The following is a description of a gene set: Mouse Gene Set: GOMF_CATALYTIC_ACTIVITY_ACTING_ON_RNA Catalytic activity that acts to modify RNA. studied in species Mus musculus, and this is the list of marker genes: Rnasek, Yars2, Tmt1a2, Tgs1, Ddx46, Ear1, Gtdc1, Eif4b, Farsb, Ang4 (NCBI Gene Id 328486), Mettl5, Dhx30, Slfn4, Henmt1, Trmt5, Ddx31, Mov10l1, Ddx42, Trmt10a (tRNA methyltransferase 10A), Qrsl1, Rpp21, Tfb1m, Dhx57, Aqr, Aarsd1 (NCBI Gene Id 69684), Mars1, Ddx56 (DEAD box helicase 56), Ankzf1, Dhx58, Tert, Tsen2, Dus4l, Nudt16l2, Top3b, Isg20, Rnase6, Rnasel, Rnase11, Xrn2, Ang5, Nsun2, Rnase10, Nop2, Ddx24, Dhx9, Slfn14, Pif1, Trmt1l, Trmt11, Polr2k (polymerase (RNA) II (DNA directed) polypeptide K), Mrm2, Rnase2b, Ptrhd1, Cmtr1, Ptrh1, Ddx55, Thumpd3, Ddx3y, Dus2, Rnase2a, Mrm3, Trmt2a, Tmt1a3 (thiol methyltransferase 1A3), Polr1h, Polr2f, Ears2, Mblac1, Fbl, Ddx49, Cars1, Yars1 (tyrosyl-tRNA synthetase 1), Ighmbp2, Ago3, Fbll1, Wars1, Dbr1, Fars2, Mrpl44, Gatc, Rpp25 (NCBI Gene Id 102614), Zc3h12b, Ddx1, Cwf19l1, Ddx51, Polr2j, Dus1l, Tyw3, Bcdin3d, Ang6, Polr2a, Brip1, Ddx41, Ddx28, Rida, Qtrt2, Piwil1, Rnh1, Mettl14, Slfn9, Ddx17, Trit1, Dars2 (aspartyl-tRNA synthetase 2 (mitochondrial)), Rexo2, Hnrnpa1 (NCBI Gene Id 52621), Trub1 (TruB pseudouridine (psi) synthase family member 1), Sars2, Nsun6, B3gntl1, Cnot6, Smg6, Ptrh2, Aars2, Cdk5rap1, Vars2, Ear2, Polr3h, Cpsf3, Cdkal1 (CDK5 regulatory subunit associated protein 1-like 1), Slfn8, Dimt1, Nsun4, Rpp30, Exd2, Dtd2, Rars2, Tsr3, Trmt13, Mettl1, Fmr1, Trub2, Lactb2, Tut1, Pld6, Tarbp1, Nob1, Trmu, Cars2, Hars2, Fdxacb1, Rnase9, Cnot8, Polr2h (NCBI Gene Id 260309), Ythdc2, Pusl1, Ern1, Dhx40, Pop4, Ddx39a, Myg1, Mov10, Pnpt1, Emg1, Tyw5, Ddx18, Ddx54, Usb1, Hars1 (histidyl-tRNA synthetase 1), Endov, Lars2, Pus10, Iars1, Ddx3x, Rpusd4, Ern2, Lrrc47, Dhx33, Polr2i, Dhx15, Dxo, Trmt61a, Trmt10b, Ggt1, Pan3, Eif4a3, Tdrd12 (NCBI Gene Id 73691), Rnase13, Ints11, Pcif1, Ddx25, Bud23, Pus7, Ddx43, Thg1l, Ddx59, Marf1, Mettl3, Piwil2, Trmt9b, Snrnp200, Prorp (NCBI Gene Id 66132), Mars2, Trmt1, Rngtt, Polr3b, Cmtr2, Eif4h, Polr1d, Mtrex, Noct, Rnaseh2a (ribonuclease H2, large subunit), Prim1, Pnldc1, Eif4a1, Qtrt1, Slfn2, Mettl16, Mepce, Eri2, Polr3k, Exog, Kars1, Ddx20, Eri3, Ear6, Dhx34, Polr2b, Rlig1, Dis3, Zc3h12d, Dhx29, Polr1a, Supv3l1, Ftsj1, Tfb2m, Pop1, Tut7, Zcchc4, Crcp, Tars2, Prorsd1, Parn, G3bp1 (NCBI Gene Id 97760), Rcl1, Ear10, Ddx52, Eprs1 (glutamyl-prolyl-tRNA synthetase 1), Rars1, Polr3a, Dis3l, Nudt12, Alkbh3, Pde12 (phosphodiesterase 12), Snd1, Lars1, Ddx5, Drosha, Dars1, Fancm, Mettl4, Polr2l, Qars1, Ear14, Alkbh1, Helz2, Dhx32, Endog, Khnyn, Rtcb (RNA 2',3'-cyclic phosphate and 5'-OH ligase), Mettl8, Tdrd9, Polrmt, Nars2, Cnot6l, Rpp38, Slfn3, Primpol, D1Pas1, Jmjd6, Slu7, Dcp2, Gm28729 (predicted gene 28729), Dis3l2, Toe1, Skic2, Ang2, Xrn1, Nsun5, Trnt1, Wars2, Ago2, Mettl15, Sars1, Slfn1, Trmt10c, Cnot7, Dhx38, Pop5, Rigi, Ddx47, Dhx8, Dtd1 (D-tyrosyl-tRNA deacylase 1), Rtca, Tars3, Nynrin, Fto, Exosc10, Trmo, Elac2, Pars2, Etf1, Ddx10, Polr1c, Nudt16, Dtwd1, Samhd1, Ddx19a, Fxr1, Zc3h12c, Upf1, Tars1, Sepsecs, Ddx27, Trdmt1, Eif4a3l2, Rnase12 (NCBI Gene Id 497106), Tsen34, Abce1 (ATP-binding cassette, sub-family E member 1), Ifih1 (interferon induced with helicase C domain 1), Mrm1 (mitochondrial rRNA methyltransferase 1), Trpt1, Pus1, Ddx6, Mtfmt, Mettl2, Dhx36, Zc3h12a, Ago4, Gatb, Apex1, Eif4a2, Ftsj3, Nars1, Ddx21, Alkbh5, Lcmt2, Dalrd3, Rnase1, Trmt44, Ddx39b, Ddx4, Dus3l, Rnaseh1, Trmt12, Polr2e, Tsnax, Pop7, Vars1, Isg20l2, Cnot2, Polr2c, Cnot1, Piwil4, Pus3, N4bp1, Tyw1, Rnaset2b, Aars1, Eri1, Nudt16l1, Iars2, Polr1b (NCBI Gene Id 320298), Endou, Mettl6, Tut4, Gars1, Ggt5, Pstk, Rnase4, Ybey, Pan2, Tmt1a, Rnmt, Mrpl58, Nsun3, Fen1, Thumpd2, Rpp14, Ddx19b, Ang, Alkbh8, Rnaset2a, Tdp2, Ddx50, Dicer1, Tmbim6, Rpp40, Farsa, Eif4a3l1 (eukaryotic translation initiation factor 4A3 like 1), Trmt2b, Dtwd2, Elac1 (elaC ribonuclease Z 1)